Given this list of marker genes RFX3, PXN, GFPT2, PTER, OMD, PNPO, CLUAP1, CAMK2D, PLA2G15, ABCA9, SRPRB, ABCF1, MFSD14B, RUNX1T1, PDS5B, MIER1, IGF1R, PPP3R2 (protein phosphatase 3 regulatory subunit B, beta), PFKFB1, ASIC1, NXPH2, KLK3, NCKIPSD, RIC8B, BRPF3, ZFYVE16, PPP3R1, BHMT, PDE2A, FAM13C (NCBI Gene Id 220965), ITGB8, PDK3, SLC24A4, ARL15, ATP6V1B2, MAP2, TXNL4B, SCML2, GRID2IP, PLD5, ADGRF5, C8orf34, AAK1, SYN2, SRSF10, VRK2, ZNF516, FRAS1, BCAT2 (branched chain amino acid transaminase 2), LHFPL6, CREBZF, DNAAF11, RIMS3, RASSF8, CYP24A1, ZHX3, SPOP, POU2F1, UBE2G1, MEF2A, MRFAP1L1, FLRT2, EBF3, TAOK3, CXCR5, SLC39A14, SSPN, GRAMD1C, IFT70A, ZHX1, CLEC4E, STK10, HOMER1, VPREB3, RNF169, STMND1, COPS3, GMCL1, ZNF236 (NCBI Gene Id 7776), STRBP, TSPAN16, MGAT3, CNBP, FRAT1, OPHN1, IGBP1, IGSF3, TMPO, PCBP2, KMO, PAG1, SH3GLB1, KAT7, MARCHF8, CDK12, FAT3, VWA2, CNTF, WDFY3, YTHDF2, KDM5A, USP31, TECRL, PCLO, SAR1A (NCBI Gene Id 56909), SLC30A8, LRRN2, GALNT1, PTGFR, MMGT1, STXBP6, LUZP1, CFLAR, DNAJC16, TAF15, RWDD3, LARP1, ERBB4, ASB3, CYLD, ITGA10, ZNF362, CA12, PTPRJ (NCBI Gene Id 5795), OAS1, UNC13A, ARHGEF12, HDAC1, GRHPR, CDS1, TFCP2L1, BCL11B, IFFO2, SYNPO2 (NCBI Gene Id 171024), KIF1B, NFIB (NCBI Gene Id 4781), ADH5, TCEAL5, TGFBR2, SCRG1, DDX23, EHF, FIGN, SEL1L, ABL2, LURAP1L, LNPK, ENTPD7, SCFD1, NSUN7, SUSD5, B4GALT6, GOSR2, HSD17B12, GNRHR, ETAA1, ADGRL1, GLIS3, TC2N, TRUB1, PIEZO2, RPN2, SLC44A1, KCNIP1, KAT2A, RHOG, FOXJ2, EGR2, UBE2W, PCDHB16 (NCBI Gene Id 57717), HYCC2, SERTM1, CAMK1D, PGAM5, FAM217B, CLEC1A, PODXL, METTL14 (methyltransferase 14, N6-adenosine-methyltransferase non-catalytic subunit), DEPDC4, FOXM1, FGFR1OP2, ZNF532, ERC2, ATP2B4, CAPRIN1, GRIA2, EIF5A2, CEP44, LYRM9, TRIM45, SLC16A7, CD84, ARL4C, TICAM2, LDLRAD3, PAN3, PLEK, SLMAP, ANKHD1 (NCBI Gene Id 79721), THUMPD1, SLC24A2, SLC4A8, SLC16A9, ACSL6, YWHAG, TRIP11, ZMAT3, MORN4, STARD3NL (NCBI Gene Id 83930, STARD3 N-terminal like), SLC7A6, DCLK1, TP53INP1, RAB15, CTNNA3, A2ML1, HLX, TTPAL, SFXN1, C18orf21, SGCZ, FZD3, LCLAT1, PERP, INTS6L, DLD, MMP8, PTBP2, DIXDC1, TTN, SMAD2, KCNS3, WWTR1, NDUFA9, MYL1, ZNF239, VPS13A, NFAT5 (NCBI Gene Id 10725), SLC35F1, PHLPP1, USP12, NDST3, ARID3A, ONECUT2, PLEKHA8, PTGER4, ATXN1, PLXDC2, PRMT6, MGAT4A, PRR3, PRSS16, DMXL2, SMS, IRS1, FAM210A, TMTC1, SRGAP3, RSBN1, KIAA0753, BICD1, PCDH19, C3orf80, APBA1 (amyloid beta precursor protein binding family A member 1), ZNF385B, ITCH, MTCL2, NTN4, GK5, ANKRA2, GFM1, BUB3, HPSE2, RPIA, ARSB, PAFAH1B1, PARD3, SNX18, HIF1AN, G3BP2, HNRNPK, KCTD12, ANLN, OLFM3, PLD1, ZWILCH, ATP2B2, SCEL, CPQ, CACHD1, ADAM22, RC3H1, TNRC6B, DLG1, IGF2BP3, NOTCH2NLA, INO80D, SNX12, SEC22B, CD96, AGTR2, FBXW11 (F-box and WD repeat domain containing 11), AKAIN1, BCL7A, TMED7-TICAM2, SLC26A8, here is a description of the gene set: species: Homo sapiens Genes predicted to be targets of miRBase v22 microRNA hsa-miR-3919 in miRDB v6.0 with MirTarget v4 prediction scores > 80 (high confidence targets). from publication Chen Y, Wang X (PMID 31504780) Human Gene Set: MIR3919